The following is a description of a gene set: studied in species Mus musculus Subdivision of the embryo along the anterior/posterior axis into anterior, posterior and terminal regions. Mouse Gene Set: GOBP_TRIPARTITE_REGIONAL_SUBDIVISION, and this is the list of marker genes: Tbx3, Pld6, Nckap1, Wt1, Tifab, Tasor, Wnt5a, Tdrd6, Tcf7l1, Fzd5, Tdrd1, Pcsk6, Cripto, Tdrd7, Tdrkh, Neurog1, Tdrd5, Frs2